Given this list of marker genes NHLRC1, EPM2A, MICAL1, RELN (NCBI Gene Id 5649), LGI1, CNTN2, here is a description of the gene set: Human Gene Set: HP_FOCAL_SENSORY_SEIZURE_WITH_VISUAL_FEATURES A seizure characterized by elementary visual hallucinations such as flashing or flickering lights/colors, or other shapes, simple patterns, scotomata, or amaurosis as its first clinical manifestation. Focal sensory seizure with visual features studied in species Homo sapiens